The following is a description of a gene set: species: Homo sapiens The specific movement from place to place of an organism in response to external or internal stimuli. Locomotion of a whole organism in a manner dependent upon some combination of that organism's internal state and external conditions. Human Gene Set: GOBP_LOCOMOTORY_BEHAVIOR, and this is the list of marker genes: ABAT, ZFHX3, CDH23, ARRDC3, EPS8, HTR2C, IDO1, ALS2, GLRA1, ROGDI, TH, SPG11, SPTBN4, GMFB, NCOA2 (nuclear receptor coactivator 2), BORCS7, DRD1, SELENOP, USP2 (NCBI Gene Id 9099), TUBA1A (tubulin alpha 1a), CNP, CHRNB4, SPG21, LGI4, HOXB8, CNTN1, APOE, CHL1, GAA, INPP5F, GRM1, OPRD1, B4GALT2, GIGYF2, ASL, DAB1, APBA1, PENK, GRM6, SLURP1, DBH, BTBD9, SCN1A, ADCY5, ARRB2, KCNJ10, AGTPBP1, APBA2, DRD4, PEX13, FKRP, TRH, ID2, NAGLU, EN1, NKX2-1, CACNB4, CLN8, TBCE, CSTB, LMX1A, CRH, CIART, PITX3, DLG4, SLC18A2, FOXA2, GNG7, NTAN1, ZMPSTE24, KLHL1, GIP, CLCN3, DRD2, MINAR2, ALDH1A3, PTEN (phosphatase and tensin homolog), CHRNA3, ETV5, AVP, ADORA2A, GPR37, PDE1B, ATP7A, APP, SLC1A1, OPRK1, FZD4, RELN, FGF12, ASTN1, SEZ6, RCAN1, PAFAH1B1, MYG1, DSCAM, GPR88 (NCBI Gene Id 54112), SNAP25, FSHR, HEXB, NPC1 (NPC intracellular cholesterol transporter 1), ABCA2, HTRA2, ZDHHC8, PPT1, ALK, EPHA4, DRD3, TSC1, NR4A2, CWH43, GNB3, ZNF385A, UCHL1, ADCY8, ZIC1 (Zic family member 1), HPRT1, GRM5, RNF170, ANKFN1, CLN6, TNR, MECP2 (NCBI Gene Id 8274), FEZF2, QRFP, OXR1, HPGDS, TMBIM4, GIT1, SOD2, SLC4A10, CEND1, KCND2, ELP6, SNCG, HIPK2, HEXA, PPP1R1B, VPS35, GRIA1 (glutamate ionotropic receptor AMPA type subunit 1, NCBI Gene Id 2890), PREX2, GDNF, PAK6, ZNF212, ANKH, LRRTM1, MTA1, EFNB3, TAL1, CALB1, WDR47, SNCA, HOXD9, GLRB, BSX, HOXD10 (homeobox D10), GAD1, CHD7, TMOD1, LARGE1, PAK5, ATP1A2, SLC25A46, DPP4, CXCL12, GNAO1, NPY2R, CTNS, PRKN, ABHD12, MEIS1, EGR1, GRIN2D, NEGR1, ELAVL4, MTOR, MYO15A, PARK7, SOBP, NTF4, DMBX1, PBX3, ATXN1, VPS13A, SLC6A3, NAV2, PPP3CB, NLGN2, ARCN1, PUM1, RCAN2, GPR52, LRRK2, FIG4, PRKCE, PLN, SOD1, GPRIN3, NTSR1, DMRT3, GRN, SLITRK6, NPY1R, STRN, NCOR1, MCOLN3 (mucolipin TRP cation channel 3), MC3R, DDHD2, CRBN, CNTN2, FXN, GHSR, CHRNB2, C1QL1, CCND2, GBX1, RASD2